The following is a description of a gene set: Norepinephrine Neurotransmitter Release Cycle Human Gene Set: REACTOME_NOREPINEPHRINE_NEUROTRANSMITTER_RELEASE_CYCLE species: Homo sapiens, and this is the list of marker genes: RIMS1, MAOA, PPFIA2, RAB3A (NCBI Gene Id 96387), SLC18A2, SNAP25, SLC22A2, SYT1, PPFIA4, UNC13B, PPFIA1, STXBP1, PPFIA3, STX1A, CPLX1, VAMP2, TSPOAP1, SLC22A1